Given this list of marker genes TWIST1, RERE, GDF11, ATP6V1B2, HEATR3, ALX1, EBF3, SATB1, SPECC1L, LRP2, FGD1, MID1, SLC35C1, ALX3, FLNA, DHX30, DEAF1, EFNB1, SYT1, here is a description of the gene set: Frontal hairline with bilateral arcs to a low point in the midline of the forehead. Widow's peak studied in species Homo sapiens Human Gene Set: HP_WIDOW_S_PEAK